Given this list of marker genes SPEF1, CFAP91, TTLL13, PLA2G3, CCDC146, CCDC65, FBXO24, ARMC2, ODAD2, KIF20A, CC2D2A, DNAH1, LRRC23, FES, TTLL5, CCDC66, CCDC40, TPPP3, CFAP58, UBE2B, DRC1, CFAP97D1, NCKAP5, DNAAF1, MARK4, PIERCE2, LRRC46, FSIP2, SPAG16, JHY, CFAP43, CFAP65 (cilia and flagella associated protein 65), CLIP1, PDCL2, DNAI1, TPPP2, PLK1, TTLL1, DNAAF3, DNAI4, GAS8, CLASP1, SPACA9, CFAP206, CCDC39, TEKT2 (tektin 2), RSPH1, CLUAP1, DNAH5, SPEF2, TTLL3, DNAH17, ODAD4, DNAAF8, DCX, DNAAF6, RSPH6A, CCDC88C, LRRC61, AAAS, TTC12, DNAI2, CPLANE2, CFAP100, TBC1D21, ZMYND10, DAW1, CDK5RAP2, ODAD3, TPGS1, DNAH8, NCKAP5L, SPAG6, LRGUK, CAPN6, HYDIN, CLXN, NAV1, DNAI3, SPAST, MAP1B, BBS2, DNAJB13, IQCG, HOATZ, TRIM46, GAS2L1, CFAP44, TOGARAM1, STK36, DNAAF4, DNAAF11, CFAP47, CHP1, CFAP74, DNAH2, CFAP46, PSRC1, MAP1S, CFAP73, ODAD1, CEP131, DNAAF10, TPPP (tubulin polymerization promoting protein), MAPRE1, RP1L1, PIERCE1, CCSER2, RP1, DNAAF2, BBOF1, CFAP157, MNS1, FOXJ1, MEIG1, GAS2L2, ZMYND12, CCDC63, DNAAF5, CCDC103, SPAG1 (NCBI Gene Id 6674), OFD1, MTCL1, DRC7, SPAG17, NEURL1, IFT56, DNAL1 (dynein axonemal light chain 1), NUMA1, DNAH7, ZNF207, CFAP57, CFAP69, RSPH4A, RSPH9, TTLL8 (tubulin tyrosine ligase like 8), TTLL6, here is a description of the gene set: Human Gene Set: GOBP_MICROTUBULE_BUNDLE_FORMATION A process that results in a parallel arrangement of microtubules. studied in species Homo sapiens